The following is a description of a gene set: Genes predicted to be targets of miRBase v22 microRNA mmu_miR_6360 in miRDB v6.0 with MirTarget v4 prediction scores > 80 (high confidence targets). Mouse Gene Set: MIR_6360 species: Mus musculus from publication Chen Y, Wang X (PMID 31504780), and this is the list of marker genes: Fosl1, Mosmo, Kcna2, Cyp2d22, Itpk1, Rab40c, Phf10, Map4k3, Inpp5a, Ythdf3, Kmt2a, Khdrbs1, Cdkn1b, Apoo, Rbsn, Sppl3, Lpp, Pla2g4a, Csnk1g3, Ctnnd1, Kif5b, Aff4 (AF4/FMR2 family, member 4), Tm9sf2 (transmembrane 9 superfamily member 2), Fyco1, Osbpl3, Kdm7a, Sos1, Nek11, Tenm4, Anln, Fcho2, Ddx6, Zfp748, Vezf1, Rictor, Stau1, Ptpn2, Ppp4r1, Extl2, Lpar1, Pcm1, Rgl2, E2f7, Gimap8, Fam83d, Lrrc34, Nckap1, Cdc23, Cfl2, Syt1, Ipo9, Gas2l3, Zbtb41, Pak4, Nmur2, Snx30, Ccdc6, Atp13a4, Cltc, Pcyt1a, Epha7, Fcsk, Zfp618, Sh2b3, Setbp1, Hsbp1, Baz1a, Exph5, Ifngr2, Irs4, Xkr8, Snx2, Acsl1, Gorab, Lamc1, Smurf2, Zfp687, Atf7, Pde4b, Tnfrsf21, Chd2, Pacsin2, Lrrc3b (leucine rich repeat containing 3B), Ccnj, Ldlr, Ppp1r37, Ibsp, Jade1, Mrpl17, Kctd3, Ctla4, Krtap3-2, Plpp4, Tardbp (NCBI Gene Id 97174)